Given this list of marker genes DDAH1, CPS1, ASS1, DDAH2, CAD, ALDH18A1, ATP2B4, OTC, here is a description of the gene set: species: Homo sapiens Human Gene Set: GOBP_CITRULLINE_METABOLIC_PROCESS The chemical reactions and pathways involving citrulline, N5-carbamoyl-L-ornithine, an alpha amino acid not found in proteins.